The following is a description of a gene set: part of: Deadenylation-dependent mRNA decay Reactome Pathway: Deadenylation of mRNA studied in species Homo sapiens Deadenylation of mRNA proceeds in two steps. According to current models, in the first step the poly(A) tail is shortened from about 200 adenosine residues to about 80 residues by the PAN2-PAN3 complex. In the second step the poly(A) tail is further shortened to 10-15 residues by either the CCR4-NOT complex or by the PARN exoribonuclease. How a particular mRNA is targeted to CCR4-NOT or PARN is unknown.<br>A number of other deadenylase enzymes can be identified in genomic searches. One particularly interesting one is nocturin, a protein that is related to the CCR-1 deadenylase and plays a role in circadian rhythms.<br>There is also evidence for networking between deadenylation and other aspects of gene expression. CCR4-NOT, for example, is known to be a transcription factor. PARN is part of a complex that regulates poly(A) tail length and hence translation in developing oocytes., and this is the list of marker genes: PAN2, PARN, CNOT9, CNOT6L, EIF4A2, CNOT1, TNKS1BP1, EIF4A1, CNOT3, EIF4B, CNOT11, TUT7, CNOT2, CNOT8, CNOT7, CNOT10, TUT4, PAIP1, EIF4G1, EIF4A3, CNOT4, PABPC1, CNOT6, PAN3, EIF4E